The following is a description of a gene set: species: Homo sapiens The chemical reactions and pathways involving dAMP, deoxyadenosine monophosphate (2'-deoxyadenosine 5'-phosphate). Human Gene Set: GOBP_DAMP_METABOLIC_PROCESS, and this is the list of marker genes: ADA, DCK, XDH, ADK, NT5C1A, PNP, DGUOK